The following is a description of a gene set: Mouse Gene Set: GOBP_PRODUCTION_OF_MOLECULAR_MEDIATOR_OF_IMMUNE_RESPONSE studied in species Mus musculus The synthesis or release of any molecular mediator of the immune response, resulting in an increase in its intracellular or extracellular levels., and this is the list of marker genes: Pagr1a, Lax1, Atad5, Cd81, Cgas, Swap70, Ercc1, Nhej1, Siglecg, Tnfsf13, Ticam1, Htr2a, Tnfrsf1b, Pcyt1a, Rasgrp1, Fzd5 (frizzled class receptor 5), Axl, Clcf1, Il1r1, Sanbr, Hk1, Shld1, Zpbp2, Epx, Tnfsf13b (NCBI Gene Id 52115), Cd37, Ripk2, Mir181b-2, Trim6, Nbn (NCBI Gene Id 27354), Pms2, Klk7, Trem1, Parp3, Batf, Fcgr4, Psen2, Trpm4, Elane, Samhd1, Il25, Nod1, B2m (NCBI Gene Id 12010), Calhm6, Syk, Kmt5c, Atg9a, Clnk, Card9, Angpt1 (angiopoietin 1), Evpl, Enpp1, Psg22, Mir181b-1, Lilrb4a, Gpi1, Epg5, Mr1, Aplf, Gimap3, Gprc5b, Arg1, Ctnnbl1, Yy1, Nr4a3, Tnfrsf14, Ndfip1, Cd55, Nsd2, Gimap5, Pgc, Il31ra, Phb1, Dennd1b, Pkp3, Wnt5a, Tlr7, Polq, Malt1, Cd160, Hspa12a, Traf6, Card11, Gba1, Traf3ip2, Dhx36, Supt6, Jak3, Il1b, Litaf, Fcgr2b, Exo1, Rtn4, Msh6, Shld2, Il27ra (NCBI Gene Id 50931), Gata3, Twist2, Mzb1, Traf2, Tirap, Casp4, Xrcc4, Twist1, Lgals4, Il2rg (interleukin 2 receptor, gamma chain), Tgfb1, Slamf9, Stat6, Tnfsf4, Sucnr1, Ighm, Mad2l2, Kctd9, Il5, Cd40, Vpreb3, Laptm5, Kit, H2-M3, Sphk2, Il18, Cd22, Tril, Cd96, Ppl, Klrh1, Rsad2, Tlr3, Il4ra, Ivl, Ezh2, Cuedc2, Gorasp2, Cyren (cell cycle regulator of NHEJ), Mmp7, Fbn1, Cd40lg, Gas6, Map3k7, Prkcz, Btk, Mlh1, Pkn1, Cd36, Tmbim6, Tnf, Fcer1a, Ung, Kmt5b, Slc11a1, Tcf3, Irf5, Hfe, Ccr6, Fam210b, Il17a (NCBI Gene Id 16171), Mir150, Galnt2, Atg5, Xbp1, Trim55, Foxp3, Cd27, Il12b, Apoa1, Nlrp3, Tgfb2, Mavs, Klk5, Slc15a4, Trp53bp1, Sirt1, Ddx21, Hmox1, Ptprc (NCBI Gene Id 19264), Exosc3, 6030468B19Rik, Rabgef1, P2rx7, Cd86, Xcl1, Il13, Dlg1, H2-T23, Spon2, Mir324, Rnf168, Il33, Crlf2, Lig4 (NCBI Gene Id 319583), Rnf8, Apoa2, Il2, Panx1, Tek, Rbp4, Arid5a, Aicda, Gcnt3, Tlr9, Myd88, Lacc1, Tlr2, Polm, Msh2, Foxp1, Exosc6, Rigi, Mcm3ap, Prg2, Ffar2, Phb2, Cd74, Il13ra1, Inava, Tgfb3, Pycard, F2rl1, Dnajb9, Sema7a, Paxip1, Vpreb1a, Lilrb4b, Hspd1, Itm2a, Pou2f2, Ddx1, Trem3, Nuggc, Casp1, Irak3, Cd28, Sash3, Bcl6, Il12a (interleukin 12a), Ptpn22, Ighe, Nlrx1, BC037156, Tlr4 (NCBI Gene Id 21898), Ifng, Icosl, Mapkapk2, Tnfaip3, Ash1l, Ephb2, Cd226 (CD226 antigen), Stx4a, Ccr2, Il13ra2, Gapt (NCBI Gene Id 238875), Smad7, Polb (polymerase (DNA directed), beta), Ccl20, Il21, Hmces, Bst2, Il17f, Nfkbiz, Fas, Slamf1, Atm, Kdelr1, Cd244a, Hpx, Il18rap, Vsir, Fosl2, Clec7a, Prkdc, Ighd, Msh3, Tnfrsf4 (NCBI Gene Id 22163), Il10, Tcirg1, Fgl2, Nod2, Il6, Ffar3, Stard7, Ebag9, Cd55b, Trex1, Acp5, Shld3, Nipal3 (NCBI Gene Id 74552), Il18r1, Tbx21, Tfrc, Fcer1g (Fc receptor, IgE, high affinity I, gamma polypeptide), Rif1, Mif, Ifnb1, Il7r, Il4, Plcg2, Ighg1, Scimp, Ube2j1